Given this list of marker genes ARHGAP42, ARHGAP30, FLCN, SCAI, KCTD10, ABL2, DLC1, RASIP1, RIPOR2, RIPOR1, MYOC, KANK1, MET, HEG1, KCTD13, CUL3, BCL6, CCDC125, STMN1, ARHGAP35, MIR223, MIR21, TNFAIP1, ITGB1 (integrin subunit beta 1), ITGA3 (integrin subunit alpha 3, NCBI Gene Id 4454), here is a description of the gene set: Human Gene Set: GOBP_NEGATIVE_REGULATION_OF_RHO_PROTEIN_SIGNAL_TRANSDUCTION Any process that stops, prevents, or reduces the frequency, rate or extent of Rho protein signal transduction. species: Homo sapiens